Given this list of marker genes OR52N4, OR8D1, OR4C5, OR2A7, OR6V1, OR2AP1, OR7A17, OR51T1, OR10J4, OR2T12, OR52B2, OR2T7, OR2M3, OR6A2, OR5M8, OR5B12, OR10C1, OR10R2, OR52K1, OR8B3, OR2T8, OR2T2, OR2T35, OR9G9, OR1K1, OR2AG1, OR4K17, OR51L1, OR4C11, OR51B5, OR6C4, OR2T10, CNGB1, OR2W5P, OR4A47, OR9I1, OR5H15, OR1J1, OR5AP2, OR2L8, GNAL, OR51H1, OR1F1, OR5F1 (NCBI Gene Id 8592), OR8I2, CNGA4, OR13C5 (NCBI Gene Id 81379), OR9G1, OR8U8 (olfactory receptor family 8 subfamily U member 8), OR51A4, OR5B3, OR14A16, OR4C12, OR7A5, OR5T3, OR5AU1, OR52B6, OR10H4, OR5L1, OR2A1, OR1P1, OR51B2, OR6S1, OR52A4P, OR1N1, OR7D2, OR10D3, OR4E1, OR4Q3, OR4S1, OR2J2, OR13A1, REEP1, OR3A3, OR2L13, OR5J2, OR51J1, OR1E2, OR2A14, OR10J1, OR2A2, OR2T5, OR5AC2, OR2M4, EBF1, OR4C13, OR2T6, OR4Q2, OR56B1, OR10H3, OR52E2, OR8K3, OR2M7, OR1A2, OR6N1, OR8A1, OR2A4, OR4K13, OR2AK2, OR1F12P, OR4C15, OR1E3, OR11H4, OR2T27, OR52N5, OR2Z1, OR4K3, OR52E4, OR51Q1, OR2AG2, OR5D14, OR52K2 (olfactory receptor family 52 subfamily K member 2), OR52W1, OR51E1, OR10H5, OR5B2, CNGA2, OR4X2, OR51F1, OR5K1 (NCBI Gene Id 26339), OR4F5, OR5AC1, OR51I1, OR13C4, OR4K14, OR2T29, OR1L6, OR4L1, OR51E2, OR4K2, OR5A1, OR6C2, OR51F2, OR56B4, OR2T33, OR11H7, OR4D11, OR2V1, OR1Q1, OR6P1, OR5I1, OR52E5, OR6C70, OR5D16, OR11G2, OR8U3, OR4D10, OR6J1, OR4F6, OR9A4, OR2S2, OR56A4, RTP2, OR10A4, OR10J5, OR6X1, GNG13, OR5V1, OR1S2 (olfactory receptor family 1 subfamily S member 2), ANO2, OR1B1, OR51S1, OR6F1, OR5K3, GNB1 (G protein subunit beta 1), OR4F17, OR7G2, OR6C6, OR6C74, OR4S2, OR1L4, OR2J1, OR52H1, OR14A2, OR12D2, OR2D2, OR10AD1, OR10AC1, OR10G3, OR2L2, OR8G1, OR5K4 (NCBI Gene Id 403278), OR4X1, OR4M2, OR2G2, OR8B2, OR6N2, OR3A2, OR9Q1, OR51B4, OR13F1 (olfactory receptor family 13 subfamily F member 1), OR10W1, OR52L2P (NCBI Gene Id 79274), OR6C3, OR2B6, OR2T3, OR51M1, OR4A5, OR5B21, OR13C8, OR4K5, OR7G3, OR2AT4, OR2V2, OR2D3, OR52N1, OR11A1, OR2K2, OR11H6, OR4N5, OR2H1, OR10AG1, OR8B4, OR2A5, OR2T11, OR7A10, OR10G7, OR1D5, OR10K2, OR51I2, OR1N2, LDB1, OR4E2, OR7A2P, OR2A12, OR5H6, OR5T1, OR6K6, OR6K2, OR8H3, LHX2, OR1D4, OR10P1, OR5M9, OR56A5, OR6Q1, OR14I1, OR10H1, OR10V1, OR13C9, OR5AR1, OR7C1, OR11H1, OR52M1, OR5M1, OR4K15, OR10Q1, OR5C1, OR5P3, OR52Z1, OR1J4, OR4A15 (NCBI Gene Id 81328), OR10G4, OR5L2, OR1A1, OR8G2P, OR2F1, OR10A7, OR52R1, OR4F15, OR1E1, OR4B1, OR5M10, OR5M3, OR10J3, OR5AS1, OR7C2, OR13G1, OR5H14, OR4D6, OR4C3, OR14K1, OR7G1, OR2B11, OR51A7, OR5M11, OR1J2, OR5P2, RTP1, OR5AK2, OR9A2, OR1I1, OR11H2, OR4P4, OR8H1, OR2T1, OR5D18, OR5AL1, OR51D1, OR2T34, OR52D1, OR2I1, OR10A5, OR1C1, OR52A5, OR1D2, OR7E24, ADCY3, OR6B1, OR4A4P, OR8K5, OR52E6, OR52J3, OR4C46, OR10S1, OR8U1, OR52I1, OR5H1, OR8B12, OR4D2, OR4D9, OR4N4, OR2H2, OR52I2, OR4C6, OR2L3, OR10A3, OR2AJ1, OR10G6, OR2B3, OR4D1, OR52N2, OR11L1, OR6C75, OR8J1, OR6T1, OR5G3, OR56A3, OR8D4, OR6C1, OR5K2, OR2Y1, OR1M1, OR14J1, OR3A1, OR13J1, OR1S1, OR51B6, OR5W2, OR52A1, OR6C68, OR10K1, OR6B2, OR10G2, OR8B8, OR10T2, OR1F12, OR6C65, OR6K3, OR4K1 (NCBI Gene Id 79544), OR9G4, OR4N2, OR9K2, OR13H1, OR2W1, OR52L1, OR5A2, OR10Z1, OR2J3, OR2W3, OR5H2, OR8G5, OR1L3, OR51V1, OR1L8, OR5B17, OR2G3, OR1G1, OR8H2, OR1L1, OR4C45, OR5T2, OR13D1, OR52E1, OR2G6, OR2A25, OR13C2, OR2B2, OR4M1, OR10G9, OR2AE1, OR8J3, OR52E8, OR51G2, OR8J2, OR6Y1, OR2F2, OR6B3, OR14C36, OR51G1, OR8K1, OR10X1, OR2M2, OR4C16, OR13C3, OR10H2, OR2C3, OR4F4 (olfactory receptor family 4 subfamily F member 4), OR4A8, OR7D4, OR10G8, OR6M1, OR12D3, OR4F21, OR6C76, OR5AN1, OR2T4, OR8D2, OR52Z1P, OR51A2, OR10A6, OR56A1, OR2L5, OR2C1 (olfactory receptor family 2 subfamily C member 1), OR8U9, OR2M5, OR9Q2, OR4F3, OR4D5, OR5D13, OR10A2, OR8S1, OR4A16, here is a description of the gene set: part of: Sensory Perception species: Homo sapiens Mammalian Olfactory Receptor (OR, also called odorant receptor) genes were discovered in rats by Linda Buck and Richard Axel, who predicted that odorants would be detected by a large family of G protein-coupled receptors (GPCRs) that are selectively expressed in the olfactory epithelium. This prediction was based on previous biochemical evidence that cAMP levels increased in olfactory neurons upon odor stimulation. These predictions proved to be accurate, and Buck and Axel received a Nobel Prize for this and subsequent work.<br>Subsequent work in mice and other vertebrates has confirmed that OR genes are comprised of a very large family of G Protein-Coupled Receptors (GPCRs) that are selectively-expressed in olfactory epithelium. Although some OR are also expressed selectively in one or a few other tissues, their expression in olfactory-epithelium generally indicates a functional role in mediating olfaction, where they couple binding by odorant ligands with intracellular olfactory signaling. (Note: the other subclasses of GPCR signaling pathways are described under "GPCR Signaling".)<br>The ligands for ORs are diverse, ranging from chemical compounds to peptides. Intracellular signaling by OR proteins in mice and other mammalian systems is known to be mediated via direct interactions of OR proteins with an olfactory-specific heterotrimeric G Protein, that contains an olfactory-specific G alpha protein: G alpha S OLPH (also named "GNAL").<br>In model genetic systems such as mice, many candidate OR genes have been shown experimentally to function in olfactory signaling. For the human OR genes, experimental analysis has been more limited, although some specific OR genes, such as OR7D4 and OR11H7P have been confirmed to mediate olfactory response and signaling in humans for specific chemical odorants. Mice and other rodents are believed to have about 1000 functional OR genes, as well as many additional pseudogenes. Based on sequence similarities, there are 960 human OR genes, but approximately half of these are pseudogenes. In mice, essentially all olfactory signaling requires G-alpha-S (OLF); mouse G-OLF knockouts have been shown to lack olfactory responses. Bona fide human OR genes identified by sequence similarity (not pseudogenes with function-blocking mutations) that are expressed in olfactory epithelium are expected to interact with G alpha S OLF containing G Protein trimers. <br>Of the 960 human OR genes and pseudogenes, there is experimental evidence that indicates over 430 are expressed in human olfactory epithelium, including 80 expressed OR pseudogenes.<br>When expressed in model cell systems mammalian olfactory receptors (ORs) are typically retained in the ER and degraded by the proteasome. A study using Caenorhabditis elegans showed that the transport of ORs to the cilia of olfactory neurons required the expression and association of ORs with a transmembrane protein, ODR4. Co-transfection of rat ORs with ODR4 enhanced the transport and expression of ORs at the cell-surface. These studies suggested that olfactory neurons might have a selective molecular machinery that promotes expression of ORs at the cells surface. Two human protein families have been identified as potential accessory proteins involved in the trafficking of ORs to the plasma membrane. Receptor transporting proteins 1 and 2 (RTP1, RTP2) both strongly induced expression of several ORs at the cell-surface. To a lesser extent, the receptor expression enhancing protein 1 (REEP1) also promoted cell-surface expression. These proteins are specifically expressed in olfactory neurons with no expression in testis, where a subset of ORs are expressed. Other members of the RTP and REEP families have a widespread distribution. RTP3 and RTP4 have been shown to promote cell-surface expression of the bitter taste receptors, TAS2Rs. REEP1 and REEP5 (also known as DP1) are involved in shaping the ER by linking microtubule fibers to the ER. A recent study looking at the role of REEP in the trafficking of Alpha2A- and Alpha2C-adrenergic receptors showed that REEP1-2 and 6 enhance the cell-surface expression of Alpha2C, but not Alpha2A, by increasing the capacity of ER cargo, thereby allowing more receptors to reach the cell-surface. Unlike RTP1, REEP1-2 and 6 are only present in the ER, do not traffic to the plasma membrane and specifically interact with the minimal/non-glycosylated forms of Alpha2C via an interaction with its C-terminus. REEPs may function as general modulators of the ER, rather than specifically interacting with GPCRs. Loss of association of REEP2 with membranes leads to hereditary spastic paraplegia.<br>Olfactory receptors (ORs, also called odorant receptors) are present on the plasma membrane of cilia of olfactory sensory neurons located in the olfactory epithelium of the nasal sinus. Each mature neuron expresses only one OR gene and each OR binds one particular volatile chemical or set of volatile chemicals, known as odorants. The binding of an odorant to an OR causes a conformational change in the receptor that activates the G alpha subunit (Golf, GNAL) of an associated heterotrimeric G protein complex to exchange GDP for GTP (inferred from mouse homologs in Jones et al. 1990). GNAL:GTP and the Gbeta:Ggamma subcomplex (GNB1:GNG13) dissociate from the olfactory receptor and GNAL:GTP then binds and activates adenylate cyclase 3 (ADCY3) (inferred from rat homologs in Bakalyar and Reed 1990, reviewed in Boccaccio et al. 2021). Cyclic AMP produced by ADCY3 binds and opens the olfactory cyclic nucleotide-gated channel (CNG channel) composed of CNGA2, CNGA4, and CNGB isoform 1b (inferred from rat homologs in Liman and Buck 1994). The CNG channel translocates sodium and calcium cations from the extracellular region into the cytosol. The resulting cytosolic calcium ions bind ANO2 and increase the transport of chloride ions by ANO2 from the cytosol to the extracellular region (inferred from mouse homologs in Pifferi et al. 2009, Stephan et al. 2009). The translocations of ions across the plasma membrane causes depolarization of the neuron yielding a receptor potential and action potential that is transmitted to the olfactory bulb of the brain. Reactome Pathway: Olfactory Signaling Pathway